The following is a description of a gene set: Detection of individual body time (BT) via a single-time-point assay has been a longstanding unfulfilled dream in medicine, because BT information can be exploited to maximize potency and minimize toxicity during drug administration and thus will enable highly optimized medication. To achieve this dream, we created a molecular timetable composed of >100 time-indicating genes, whose gene expression levels can represent internal BT. Here we describe a robust method called the molecular-timetable method for BT detection from a single-time-point expression profile. The power of this method is demonstrated by the sensitive and accurate detection of BT and the sensitive diagnosis of rhythm disorders. These results demonstrate the feasibility of BT detection based on single-time-point sampling, suggest the potential for expression-based diagnosis of rhythm disorders, and may translate functional genomics into chronotherapy and personalized medicine. from publication Ueda HR, Chen W, Minami Y, Honma S, Honma K, Iino M, Hashimoto S (PMID 15273285) species: Mus musculus Mouse Gene Set: UEDA_CENTRAL_CLOCK Molecular timetable composed of 96 time-indicating genes (103 probes) in the central (suprachiasmatic nucleus (SCN)) clock., and this is the list of marker genes: Rbm3, Caprin1, Pkib, Per2, Rexo2, Syt17, Hspa1a, Cry1, Hnrnpm, Stx5a, Plk2, Tubgcp4, Psmd5, Cdk2ap2, Stat3, Dlk1, Gadd45g (growth arrest and DNA-damage-inducible 45 gamma), Ccl7, Plekha1, Manf (mesencephalic astrocyte-derived neurotrophic factor), Nsdhl, Dusp1, Chordc1, Zbtb14, P4ha1, Rora, Blcap, Tuba8, Tprg1l, Pdcd4, Per1, Igfbp5, Sfrp2, Akap17b, Avpr1a, Fabp7, Crybg1, Man2a1, Rab34, Cmbl, Xbp1, Herpud1, Hspa5, Dnajb1, Hspd1, Id2, Rabep1, Pdia6, Hsph1 (heat shock 105kDa/110kDa protein 1), Hspa1b, Gadd45b, Sox7, Polr2e, Rasd1, Sgk1, Phka1, Sqle, Hrh2, H3f3b, Gadd45a, Bckdhb, Rps4l, Ubqln1, Rnaset2b, Calcr, Avp, Smpdl3a, Rpn2, H2-Eb1, Ormdl1, Thrap3, Cxcl12, Srsf6, Rgs16, Abcd2, Nr1d2, Bmpr1a, Tmem30a, Stk24, Ccl21a, Bmal1, Ap1b1 (adaptor protein complex AP-1, beta 1 subunit), Dhodh, Dbp, Mrpl41, Ubfd1, Nfil3, Ppp1r1a, Ube2s, Hmgb3, Rasl11b